Given this list of marker genes IRF2, PRKRA, PHF13, C16orf95, TMED8, SLCO3A1, TCF7, CNR2, LRRC8C, MRGPRE, MPND, FRAT1, POU6F1, RGL2, TRIB2, RASSF2, DGKD, ACTRT2, LBH, CDC42EP3, CD300A, ADD3, PPDPF (pancreatic progenitor cell differentiation and proliferation factor), MYO1C, SESN1, CDC42SE1, MAP4K2 (NCBI Gene Id 5871, mitogen-activated protein kinase kinase kinase kinase 2), GMIP, HLX, CSK, OXLD1, RB1CC1, GPR34, PIANP, CREBL2, KDM2A, H3C4, CTPS2, TMEM106B, PRPH, CCDC82, P2RY13, SPIB, HHEX, MAP3K14, TFEB, NOXO1, CYFIP1, MAN1A1, SLC8B1, C12orf57, IFT140, KLF2, PARP4, SLC44A1, SH2D3C, HSD17B11, AQP11, ABCB4, LPP-AS2, C1QB, C15orf39, NDRG2, HECA, PNRC1, ARRDC1, RNF38, SCML4, CD38, MAPK11, FCGR2B, BEST1, ACAP1, RASGRP1, PIAS3, LYNX1, ZNF260 (NCBI Gene Id 339324), FCRLA, INCA1, MIDEAS, ACR, TBC1D2B (NCBI Gene Id 91449), NPPC, ZNF395, SMIM14, RAB1B (RAB1B, member RAS oncogene family), SFXN3, GNGT2, RB1, MSN, STING1, SNCAIP, DTX1, B3GNT8 (NCBI Gene Id 374907), PTPRO (NCBI Gene Id 5800), SYK, CDC42SE2, AOC1 (amine oxidase copper containing 1), MINDY2, SMC6, ACOT13, MSRB3, MAK, TNFAIP8L2, COQ8A, RP2, RETREG1, GIT2 (GIT ArfGAP 2), ELF4, TNRC6C, ADAMTS10, PLEC, STK10, LAT2, MYH9, HPCAL1, NUMA1, SGMS1, RNF181, CYTIP, APLP2, RPS6KA5, MXI1, INPP5K, JUND, GUCD1, ABCA1, CCND3 (NCBI Gene Id 896), EVI5, ITGB1BP2, SERP1, ZMYM2, TACC1, SIAE, BAZ2B, KDF1, POLD4, C1orf54, CSF1R, RPL39, CD19, SEMA4B, TSC22D3, RALGPS2, RNF130, ADAM8, IL6R, TMEM151A, GAB3, ABHD17A, PRSS23, ICOSLG, DENND2D, FAM234B, TSPAN32, KLC4, WNT11, KDM3B, SNX8, SPTBN4, ERCC5, GRK2, GRAMD4, SLC25A53, SIRT3, H3-5, HAUS4, HIP1R, WASF2, UGDH, SPATA6, PURG, ANKRD13A, ZNF784, RALBP1, RCHY1, FRMD8, MARVELD1, PDE2A, BNIP3L (NCBI Gene Id 9257), ING4, MKNK2, TRMT2B, RNF167, RCSD1, PTPRCAP, SERTAD3, PPP3CA, PTPRJ, PPOX, BMF, PLCG1, UNC13D, TPT1, GPR137B, SASH3, KCTD12, PDCD4, SUSD1, ID3, here is a description of the gene set: CD4 T follicular helper (Tfh) cells provide the required signals to B cells for germinal center reactions that are necessary for longlived antibody responses. However, it remains unclear whether there are CD4+ memory T cells committed to the Tfh lineage after antigen clearance. Using adoptive transfer of antigen-specific memory CD4+ subpopulations (based on CXCR5 and Ly6c expression)in the LCMV infection model, we found that there are distinct memory CD4+ T cell populations with commitment to the Tfh and Th1 lineages. Our conclusions are based on gene expression profiles, epigenetic studies and phenotypic and functional analysis. The gene expression profiles of virus-specific CD4 T cell subets at effector and memory stages is presented here. species: Homo sapiens Human Gene Set: GSE43863_NAIVE_VS_MEMORY_LY6C_INT_CXCR5POS_CD4_TCELL_D150_LCMV_UP Genes up-regulated in CD4 SMARTA T cells: naïve versus Ly6c int CXCR5+ memory. from publication Hale JS, Youngblood B, Latner DR, Mohammed AU, Ye L, Akondy RS, Wu T, Iyer SS, Ahmed R (PMID 23583644)